Given this list of marker genes Ubxn7, Ccne2, Zdhhc9, Smg5, Rab23, Six4, B3gat1, Ube2z, Ythdf1, Pak1ip1, Reep5, Nfkbiz, Hyou1, Wapl, Pias1, Col14a1, Cstf3, Bdnf, Luc7l3, Dnlz, Ar, Prkcb, Adgrl3, Tm9sf2, Osgin2, Nup98, Cks1b, Vash1, Odc1, Zmpste24, Shisa6, Dab1, Ube2l3, Rnf144b, Prpf4b, Notch1, Sema6a, Mocs2, Gnal, Bptf, Dsc3, Tbck, Pdap1, Dtd1, Rhobtb3 (Rho-related BTB domain containing 3), Slc30a4, Pgbd5, Mapk8, Cops2, Kdr, Kat7, Vapa, Klhl31, Dok4, Dnaaf10, Pum2, Phactr2, Mcee, Zfp354b, Terf2ip, Mtx3, Zfp874a, Tmem158, Zfp9, Nfat5 (NCBI Gene Id 54446), Arhgap33, Lox, Atrx, Tktl1, Zfp874b, Usp32, Pik3c2a, Fermt3, Cox7b, Mospd1, Nrbp2, Odr4, Mtcl2, Smap2, Elp4, Vps4b, Thsd7b, Nlgn1, Fggy, Timp3, Aplnr, Grm5, Ahsa2, Tmem86b, Ube2g1, Shoc2, Zfp91 (zinc finger protein 91), Eml4, Reps2, Rcan1, here is a description of the gene set: Genes predicted to be targets of miRBase v22 microRNA mmu_miR_3084_3p in miRDB v6.0 with MirTarget v4 prediction scores > 80 (high confidence targets). from publication Chen Y, Wang X (PMID 31504780) species: Mus musculus Mouse Gene Set: MIR_3084_3P